Given this list of marker genes NLGN1, NLGN2 (NCBI Gene Id 57555), RPH3A (NCBI Gene Id 22895), ARC, MAPK1, GRIN2D, FMR1, GRIN2C, CAMK2A, CAMK2G, DLG2, NLGN3, DLGAP1, SHANK1, NRXN2, CAMK2D, DLG1, HOMER1 (NCBI Gene Id 9456), CYFIP1, TJP1, NRXN1, GRIN2A, RYR2, NLGN4X, NRXN3, STX1A, SYNGAP1, GRIN2B, CAMK2B, MAPK3, YWHAG (tyrosine 3-monooxygenase/tryptophan 5-monooxygenase activation protein gamma), GRM1 (glutamate metabotropic receptor 1), GRIN1, here is a description of the gene set: Human Gene Set: WP_DISRUPTION_OF_POSTSYNAPTIC_SIGNALING_BY_CNV Disruption of postsynaptic signaling by CNV species: Homo sapiens